Given this list of marker genes MCM6, NBN, CDK2, TICRR, MCM7, MCM2 (minichromosome maintenance complex component 2), MCM5, MCIDAS, GMNC, GMNN, CIZ1, WRNIP1, MCM4, CDT1, MCM3, KAT7, here is a description of the gene set: Any process that modulates the frequency, rate or extent of initiation of DNA-dependent DNA replication; the process in which DNA becomes competent to replicate. In eukaryotes, replication competence is established in early G1 and lost during the ensuing S phase. Human Gene Set: GOBP_REGULATION_OF_DNA_TEMPLATED_DNA_REPLICATION_INITIATION species: Homo sapiens